The following is a description of a gene set: Human Gene Set: REACTOME_INTERFERON_GAMMA_SIGNALING Interferon gamma signaling studied in species Homo sapiens, and this is the list of marker genes: TRIM26, HLA-H, TRIM10, MAPK1, HLA-DRB4, IFI30, HLA-DRB5, YBX1, PTPN2, GBP2, CAMK2D, TRIM68, ICAM1, HLA-DRB1 (major histocompatibility complex, class II, DR beta 1), HLA-DRA, TRIM8, NCAM1, TRIM29, TRIM34, IRF3, OAS2, TRIM48, HLA-DPA1, IRF6, GBP3, PIAS1, CIITA, GBP1, OAS3, GBP4, TRIM35, PTPN6, TRIM17, STAT1, SP100, HLA-DQB2, TRIM5, PRKCD, FCGR1A, IFNG, OASL, TRIM38, PTAFR, HLA-DQA1, IRF9, IRF4, TRIM6, FCGR1BP, VCAM1, TRIM3, SMAD7, TRIM22 (NCBI Gene Id 10346), CAMK2B, HLA-B, PTPN1, GBP7, CD44, PTPN11, IFNGR2, TRIM21, HLA-DQB1, OAS1, TRIM45, CAMK2G, GBP5 (NCBI Gene Id 115362), HLA-C, TRIM25, IFNGR1, IRF2, IRF5, HLA-A, SOCS1, IRF8, JAK2, HLA-DRB3, TRIM14, SUMO1, MID1, HLA-G, MT2A, HLA-DQA2, HLA-E, HLA-F, MAPK3, JAK1, TRIM31, PML, B2M, IRF1, CAMK2A, TRIM46, TRIM2, IRF7, TRIM62, GBP6, SOCS3, RAF1, HLA-DPB1